The following is a description of a gene set: Mouse Gene Set: REACTOME_ACTIVATION_OF_THE_PHOTOTRANSDUCTION_CASCADE studied in species Mus musculus Activation of the phototransduction cascade, and this is the list of marker genes: Gnb1, Rho, Gnat1, Gngt1, Cngb1, Pde6b, Pde6g, Cnga1